The following is a description of a gene set: species: Homo sapiens Metabolic related genes that showed positive correlation with MYC expression in CRC tissues Our transcriptome analyses of paired normal and tumor tissues from 41 patients with colorectal cancer showed that metabolic reprogramming of colorectal cancer is caused chiefly by aberrant MYC expression, which induced at least 215 metabolic reactions by changing the expression levels of metabolic genes and transporter genes. Further, MYC negatively regulated the expression of genes involved in mitochondrial biogenesis and maintenance but positively regulated genes involved in DNA and histone methylation. Knockdown of MYC in colorectal cancer cells reset the altered metabolism and suppressed cell growth. from publication Satoh K, Yachida S, Sugimoto M, Oshima M, Nakagawa T, Akamoto S, Tabata S, Saitoh K, Kato K, Sato S, Igarashi K, Aizawa Y, Kajino-Sakamoto R, Kojima Y, Fujishita T, Enomoto A, Hirayama A, Ishikawa T, Taketo MM, Kushida Y, Haba R, Okano K, Tomita M, Suzuki Y, Fukuda S, Aoki M, Soga T (PMID 28847964) Human Gene Set: SOGA_COLORECTAL_CANCER_MYC_UP, and this is the list of marker genes: PAICS, SHMT2, ADCY3, AMPD2, CTPS1, NUDT5, GLO1, B4GALT2, LDHB, TYMS, NME1, MTR, DHODH, PYCR1, DUT, SLC12A9, ALDH1B1, SLC4A2, POLR3K, PPAT, ATIC, TST, SLC25A19, SLC19A1, PRPS2, SLC7A6, POLD1, POLE3, AGK, SRM, AHCY, SLC7A1, CDK4, ENOPH1, ODC1, POLR2I, SLC25A32, IMPDH1, GMPS, ADSL, GPI, HPRT1, PRIM1, POLA2, SLC7A5, PFKM, RPIA, PYCR2, UCKL1, POLR2D, SLC25A17, MTHFD1L, POLA1, MTHFD2, SLC12A8, PYCR3, ENO1, SLC25A14, GART, PFAS, PRPS1L1, POLD2, UMPS, POLR1E, SLC25A15, SLC39A6, ASNS, POLR1D, POLE2, POLR1H, SLCO4A1, ATR, GNPNAT1, MECR, CAD (NCBI Gene Id 790), DTYMK, POLR1B, POLR3H, PNPT1, RRM1, GNPDA1, PPT1